The following is a description of a gene set: studied in species Homo sapiens The covalent alteration of one or more nucleotide sites in DNA, resulting in a change in its properties. Human Gene Set: GOBP_DNA_MODIFICATION, and this is the list of marker genes: DNTT, EXOSC5, APOBEC3G (apolipoprotein B mRNA editing enzyme catalytic subunit 3G), MPG, NEIL2 (nei like DNA glycosylase 2), AICDA, EXOSC4, UNG, NTHL1, APOBEC3F, APOBEC3C, APOBEC3D, OGG1, MBD4, TDG, APOBEC3H, CDADC1, PARP1, TREX1, EXOSC3, APOBEC3A, PARP3, PARP2, SMUG1, NEIL3, EXOSC6, APOBEC3B, NEIL1, MUTYH